The following is a description of a gene set: A process required for sperm to reach fertilization competence. Sperm undergo an incompletely understood series of morphological and molecular maturational processes, termed capacitation, involving, among other processes, protein tyrosine phosphorylation and increased intracellular calcium. Mouse Gene Set: GOBP_SPERM_CAPACITATION species: Mus musculus, and this is the list of marker genes: Tmprss12, Slc26a3, Semg1, Tcp11, Ropn1l, Pebp1, Defb1, C2cd6, Calca, Defb37, Svs3b, Catsper3, Spink1, Rnase9, Iqcf1, Efcab9, Catspere2, Abhd2, Svs3a, Cabyr, Bsph1, Adam7, Slc22a14, Catsper4, Catsper2, Pcsk4, Catsperd, Dld, Ccr6, Bsph2, Cftr, Catsperz, Catsperb (NCBI Gene Id 271036), Ropn1, Spinkl, Tssk3, Catspere1, Septin4, Prkaca, Slc26a6, Tcp11x2